Given this list of marker genes CHST15, IZUMO1R, MAPK6, SH3YL1, FZD10, SLC13A4, GML, ITGA9, ORAI2, ZNF318, MIR15B, CD200, SMC2, EOMES, SPAG1, MAP4K4, TAF5, BCL9, NOD1 (NCBI Gene Id 10392), CAMKK2, RGS3, SSBP3 (NCBI Gene Id 55126), PLSCR1, DUSP6, HACL1, TRIM9, PTTG1IP, HIVEP3, FURIN, RFC1, PTPN12, FMNL1, RSF1, LYSMD1, GSTO1, EMC3, FBH1, GPR83, DCTN4, BDKRB2, MAP3K2, HOOK1, MCOLN1, SHISAL2B, DDX23, PCED1A, TNFRSF9, TGFBR3, SMC6, HSPA4L, ST8SIA1, GRAMD1B, NR4A1, CROT, CCR8, KLB, CASP6, NOTCH1, RABL3, GRSF1, SUZ12, CD5, CEBPZ, PTK2B, SYPL1, GET4 (guided entry of tail-anchored proteins factor 4), ZNRF1, REPS1, MAN1C1, URI1, TOP2A, NUDT13, IKZF2, RNF149, MARCKS, GPR88, ZFP37, ARMC5, CTLA4, TSC22D2 (NCBI Gene Id 9819), PIK3CD, PHACTR2, ARHGAP18, TBX1, APOA2, SWAP70, TTC3, LRRK2, PFKFB3, CD6, FBXL19, SBK2, IRAG2 (NCBI Gene Id 650574), DUSP1, ST3GAL4, CDK5R1, PLCG1, MYB, KDM4A, E2F8, RNF2, GFI1, SYT11, SERP1, H2AC15, RAB13, SMPD3, SENP7, HTR2C (NCBI Gene Id 3358), DGKZ, PUS3, DHRS3, SGPP2, GIT2, RANBP3L, IL2RB, TNFSF9, ZRANB1, LPCAT1, UGGT1, CEP152, PTPN23, NAA35, MAP4K5, ITIH5 (inter-alpha-trypsin inhibitor heavy chain 5), KCTD12, CD38, OBI1, CBR3, ID2, CBX1, MAPKAPK2, XCL1, MIRLET7G, RGS16, CNPY3, JARID2, CYP51A1, KRTAP6-2, EWSR1, PFKFB4, CEP97, TNFRSF4, EPHX1, ANKRD12, SBNO2, XKRX, UTF1, SPAG17, KCNF1, GULOP, ADAR, DNMT3A, TNIK, TNIP2, SKI, SLC9B2, ITM2A, MIR592, ATP10A, FAM53B (family with sequence similarity 53 member B), STAT5B, here is a description of the gene set: Genes up-regulated in hematopoietic stem cells versus granulocyte-monocyte progenitors. Human Gene Set: GSE37301_HEMATOPOIETIC_STEM_CELL_VS_GRAN_MONO_PROGENITOR_UP Expression profiling of Rag2-deficient Ets1++ and Rag2-deficient Ets1-- mature NK cells and WT bone marrow progenitors, WT T cells, and WT Pro B cells from publication Ramirez K, Chandler KJ, Spaulding C, Zandi S, Sigvardsson M, Graves BJ, Kee BL (PMID 22608498) studied in species Homo sapiens